The following is a description of a gene set: Mouse Gene Set: REACTOME_ALPHA_PROTEIN_KINASE_1_SIGNALING_PATHWAY Alpha-protein kinase 1 signaling pathway studied in species Mus musculus, and this is the list of marker genes: Uba52rt, Ubb, Alpk1, Uba52, Ubc, Map3k7, Tifa, Rps27a, Tab1, Traf6, Tab3, Tab2